The following is a description of a gene set: studied in species Homo sapiens A process in which lipids are taken up from the contents of the intestine. Human Gene Set: GOBP_INTESTINAL_LIPID_ABSORPTION, and this is the list of marker genes: ABCG8, CLDN15, APOA4, LEP, APOA1, PRAP1, SCARB1, CYP8B1, ENPP7, APOA2, PNLIP, NPC1 (NCBI Gene Id 4864), SOAT2 (sterol O-acyltransferase 2), FABP2, AKR1C1, LDLR, LIMA1, LPCAT3 (NCBI Gene Id 10162), CEL, CLDN2, CD36, ABCG5, UGCG, NPC1L1